Given this list of marker genes Acot8 (NCBI Gene Id 170789), Hsd17b4, G0s2, Fgf21, Cpt2, Ehhadh, Etfdh, Cpt1b, Aldh3a2, Eci1, Hmgcs2, Acadm, Decr1, Decr2, Cd36 (CD36 molecule), here is a description of the gene set: from publication Sanderson LM, Degenhardt T, Koppen A, Kalkhoven E, Desvergne B, Müller M, Kersten S (PMID 19805517) Peroxisome proliferator-activated receptor alpha (PPARalpha) is an important transcription factor in liver that can be activated physiologically by fasting or pharmacologically by using high-affinity synthetic agonists. Here we initially set out to elucidate the similarities in gene induction between Wy14643 and fasting. Numerous genes were commonly regulated in liver between the two treatments, including many classical PPARalpha target genes, such as Aldh3a2 and Cpt2. Remarkably, several genes induced by Wy14643 were upregulated by fasting independently of PPARalpha, including Lpin2 and St3gal5, suggesting involvement of another transcription factor. Using chromatin immunoprecipitation, Lpin2 and St3gal5 were shown to be direct targets of PPARbeta/delta during fasting, whereas Aldh3a2 and Cpt2 were exclusive targets of PPARalpha. Binding of PPARbeta/delta to the Lpin2 and St3gal5 genes followed the plasma free fatty acid (FFA) concentration, consistent with activation of PPARbeta/delta by plasma FFAs. Subsequent experiments using transgenic and knockout mice for Angptl4, a potent stimulant of adipose tissue lipolysis, confirmed the stimulatory effect of plasma FFAs on Lpin2 and St3gal5 expression levels via PPARbeta/delta. In contrast, the data did not support activation of PPARalpha by plasma FFAs. The results identify Lpin2 and St3gal5 as novel PPARbeta/delta target genes and show that upregulation of gene expression by PPARbeta/delta is sensitive to plasma FFA levels. In contrast, this is not the case for PPARalpha, revealing a novel mechanism for functional differentiation between PPARs. Hepatic genes regulated by fasting or in response to WY14643 and which require intact PPARA. Mouse Gene Set: SANDERSON_PPARA_TARGETS studied in species Mus musculus